Given this list of marker genes Ntrk2, Chek2, Mcl1, Sik1, Tle5, Pik3ca, Bcl2l1, Ankrd13c, Pdk4, Notch1, Snai2, Itga5, Ptk2, Cryba1, Mybbp1a, Brms1, Cav1, Bcl2, Src, Itgb1, Tle1, Ptrh2, here is a description of the gene set: Any process that modulates the frequency, rate or extent of anoikis. Mouse Gene Set: GOBP_REGULATION_OF_ANOIKIS studied in species Mus musculus